The following is a description of a gene set: Mouse Gene Set: chr4D1 species: Mus musculus, and this is the list of marker genes: Snord55, Prdx1, Skint3 (NCBI Gene Id 195564), Mast2, Tesk2, Tmem53, Kif2c, Lrrc41, Gm23230, Foxd2, Cyp4a28-ps, Gm12830, Gm12814, Nasp, Gm12828, Foxd2os, Gm12818, P3r3urf, Gm26330, Skint4, Gm12805, Eif2b3, Ccdc163, C530005A16Rik, Mknk1, Gm12834, Lurap1, Gm12993, Gm12821, Pomgnt1, Pik3r3, Pdzk1ip1, Zswim5, Gm12817, Armh1, Bend5, Skint6, Rps8, Dmbx1, Uqcrh, Akr1a1, Mutyh, Cyp4a29, Ptch2, Gm12996, Skint9, Gm12825, Gm12961, Plk3, Snord38a, Gm12804, Faah, Efcab14, Stil, Gm12827, 9130410C08Rik, Best4-ps, Rpl36-ps8, Llph-ps1, Gm25137, Gm13015, Dynlt4, Ipp, Cyp4a32, Gm12813, Gm23143, Cyp4a12a, Cyp4b1, Cyp4a31, Skint2, Cyp4a30b, Slc5a9, Gm15741, Gm12833, Foxe3, Gm12848, Gm12829, Skint7, Gpbp1l1, Gm12819, Gm12826, Toe1, Cmpk1, Gm12998, Btbd19, Cyp4x1, Gm12837, Tmem275, Rnf220, Cyp4a30-ps, Ccdc17 (NCBI Gene Id 631254), Skint1, Gm12950, Skint11, Gm12816, Cyp4a12b, Cyp4b1-ps1, Tspan1, Kncn, Mmachc, Hpdl, 1700021J08Rik, Gm12843, Cyp4a10, Mob3c, Tex38, Gm12854, Skint10, Skint8 (NCBI Gene Id 639774), Rad54l, Gm12960, Skint5, Spata6, Gm22335, Eri3, Atpaf1, Gm12838, Hectd3, Cyp4b1-ps2, Cyp4x1os, Nsun4, Cyp4a14, Trabd2b, Gm22980, Urod, Tmem69, Tal1, Gm12997